The following is a description of a gene set: part of: Intra-Golgi and retrograde Golgi-to-ER traffic species: Homo sapiens The trans-Golgi network is the docking site for retrograde cargo from the endolysosomal system and the plasma membrane. Typical cargo includes recycling resident TGN proteins such as TGOLN2 (also known as TGN46), receptors such as the mannose-6-phosphate receptors and toxins like Shiga, cholera and ricin which use the retrograde trafficking machinery to 'hitchhike' back through the secretory system for release into the cytoplasm. These cargo are trafficked from the endocytic system in a clathrin- and AP1-dependent manner that is described in more detail in the "Trans-Golgi network budding pathway" (just not yet). In general, it appears that vesicles are uncoated prior to their tethering and fusion at the TGN. At the TGN, at least 2 distinct tethering pathways exist. A RAB6-dependent pathway contributes to the fusion and docking of vesicles from the early endocytic pathway. These vesicles, which carry cargo such as TGOLN2 and toxins, dock at the TGN through interactions with TGN-localized Golgin tethers and with the multisubunit tethering complexes COG and GARP. In contrast, mannose-6-phosphate receptors appear to traffic from late endosomes to the TGN through a RAB9- and PLIN3-dependent pathway. Vesicles are recruited to the TGN through interaction of RAB9 with the atypical RHO GTPase RHOBTB3, and tethered by virtue of interaction with TGN-localized Golgins and the GARP complex Reactome Pathway: Retrograde transport at the Trans-Golgi-Network, and this is the list of marker genes: GCC2, VTI1A, VAMP4, STX16, ARL1, VPS54 (VPS54 subunit of GARP complex), NAPB, RAB6B, SCOC, NAA38, VAMP3, GOLGA4, RAB9B, COG5 (NCBI Gene Id 10466), IGF2R, RAB6A, GCC1, COG6, RABEPK, RHOBTB3, ARFRP1, COG3, COG4, RAB9A, NAPA, ARFIP2, VPS53, NSF, COG2, SYS1, TMF1, VPS52, RGP1, STX6, USP6NL, COG1, M6PR, GOLGA1, RAB43, RIC1, STX10, TGOLN2, COG8, NAA30, COG7, VPS51, NAPG, PLIN3, NAA35